Given this list of marker genes Fubp1 (far upstream element (FUSE) binding protein 1), Mrpl17, Napa, Trnau1ap, Eprs1, Eif3c, Gmppb, Sema4d, Tcof1, Nop14, Eif3j1 (NCBI Gene Id 98779), Rflnb, Uqcr10, Cd79b, Hipk2, Hsp90ab1 (NCBI Gene Id 98078), Ndufs2, Socs1, Nsun2, Pax5, Kras, Psma6, Llph (NCBI Gene Id 66225), Ran, Cyp51, Ascc3, Zc3h15, Ddx50, Chchd1, Fam136a, Ptpn2, Ptges3, Esf1 (NCBI Gene Id 99391), Ruvbl1, Taf1d, Mrpl54, Ppan, Camk2d, Btf3, M6pr, Nedd9, Cars1, Ciita, Dnajb11, Pdcl3, Pdcd11, H2-Eb1, Fkbp2, Parl, Psmd2, Hnrnpdl, Tomm40, Rtf1, Cd83, Wdr3, Romo1, Mfsd14a, Slc1a5, Snrpa1, Ddx21, Nsmce1, Hnrnpk, Cyc1, Rbm3, Mybbp1a, H2-DMa, Abcf1, Lamp2, Snrpe, Psmb5, Larp1, Raly, Utp15, Psmg4, Nup43, Sec62, Rrp12, Msh6, Gar1, Plbd1, Crebzf (NCBI Gene Id 70721), Drap1, Brd2, Utp14a, Nubp1, Psmd12, Hyou1, Ppie, Gmps, Jagn1, Abcf2, Psmd6, Noc3l, Cdv3, Timm8b, Timm10, Sigmar1, Elac2, Iars1, Pfdn2, Nol12 (nucleolar protein 12), Htatsf1 (NCBI Gene Id 76595), Psmd11 (proteasome (prosome, macropain) 26S subunit, non-ATPase, 11), Nip7, Psmc3, Atp5pf, Eif3b, Atic, Slc9a8, H2-Ab1, Cdk4, Ddit3, Rrs1, Naa20, Xpot, Atp5mc1, Bsg, Nolc1, Slc35b1, Nucks1, Atf4, Atp2a2, Timm8a1 (NCBI Gene Id 30058), Polr1g, Sbno1, Hdgf, Tkt, Bccip, Banf1, Cebpz, Syncrip, Agpat5, Hsp90b1, Las1l, Cops4, Pebp1, Ccdc86, Map4k1, Ndufa1, Ezr, Idi1, Jund, Mir142hg, Cetn3 (NCBI Gene Id 12626), Ndufa12, Nop2, Pip4p1, Eif2s1, Tmed10, Srsf9, Chmp4b, Lsm12, Txndc15, Ppp3cc, Nudt21, Rpf2, Atp5f1e, Rexo2, Tomm6, Rad23a, Sf3b3, Hnrnpa3, Sra1, Atp5f1b, Psme2, Wdr18, Kpnb1, Tmed2, Cycs, Smc1a, Dhx40, Rnf7, Smyd5, Tmed8, Wdfy2, Bub3, P4hb, Srsf6, Rrp9, Cfl1, Anp32b, Nudc, Pprc1, Tmem258, Snrpa, Psmb6, Pdap1, Tcf12, Slc7a1, Bag5, Eno1, Xbp1, Psmb3, Trmt61a, Ctsz, Ndufa5, Sdf2l1, Gpatch4 (G patch domain containing 4), Kti12, G3bp1, Eftud2, Ufm1, Eif4a3, Cltc, Rcl1, Exosc1, Srsf7 (NCBI Gene Id 60426), Mrto4, Zfp593, Cdk2ap1, Zfp62, Isca2, Wdr74, Rrp15, Klhdc2, Sar1a, Tma16, Fasn, Mrpl3, Dcun1d5, Metap2, Xylt1, Srrm1, Ssr4, Mars1, Bcl7c (NCBI Gene Id 233901), Prelid3b, Hspd1, Set, Snrpd2, Sumo2, Pelp1, Serbp1, Mrps17, St7, Ybx1, Usp10, Srm, Ifi35, Prmt7, Eif4g1, Pxdc1, Eef1b2, Htt, Rnmt, Taf4, Ldha, U2af2, Ass1, Hmgb1, Noc2l, Rrp1, H2-DMb1, Rbm8a, Dock10, Gars1 (NCBI Gene Id 353172), Rce1, Atg3, Ppp1r15b, Rbm19, Ddx39a, Nat10, Ints6, Wdr75, Lman2, Mettl1, Rbmxl1, Snrpb, Tmem123, Snx8, Uqcr11, Cct3, Snrpf, C1qbp, Ostc, Psmb7, Manf, Slc15a3, Cstf2t, Samsn1, Ube2i, Canx, Mrpl55, Ube2s, Mogs, Stt3b, Psmb2, Ppig, Eif3a, Pla2g12a, Cct2, Spcs3, Pdia3, Eif1a, Thap12, Ncoa3, Mfsd5, Aggf1, U2af1, H2-Aa, Vars1, Hnrnpd (NCBI Gene Id 330135), Uqcrb, Eif5b, Tgfbr1, Npm3, Eif2s3x (eukaryotic translation initiation factor 2, subunit 3, structural gene X-linked), Psmd7, Ubl4a, Bola2, Hspa5, Sdad1, Mthfd2 (NCBI Gene Id 17768), Ccdc115, Ankrd49, Eif2s2, Hnrnpa0, Sars1, Dhx15 (DEAH-box helicase 15), Otulin, Apex1 (apurinic/apyrimidinic endonuclease 1), Wdr46, Atp5f1c, Ubxn4, Rbm17, Bmp2k (BMP2 inducible kinase), Dnajc2 (DnaJ heat shock protein family (Hsp40) member C2), Fdps, Ndufb2, Glrx3, Gspt1, Spcs2, Atp5mc3, Pou2af1, Rheb, Pes1, Nifk, Nmt1, Cox5a, Gtf2f1, Pdia4, Fbxo28, Usp4, Nhp2, Golga4, Gnl3, Polr1f, Idh3b, Syngr2, Vmp1, Pgam1, Senp6, Vkorc1l1, Diablo, Nr2c2ap, Vcp, Smim7, Snrpd3, Nme1, Ctu2, Psma7, Eif4e2, Mcm5, Sem1, Rasa2, Tuba4a, Foxn3, Nob1, Alkbh1, Mrpl35, Chchd2, Cct8, Mrfap1, Mrps18a, Srpk1, Hnrnpa2b1, Vapa, Fbxw7, Hspe1, Prdx1, Arhgdia, Rsl1d1, Ccdc59, Trappc4, Ak2, Nudt19, Hsd17b12, Cnr2, Tars1, Cfdp1, Erh, Ranbp1, Ssb, Npm1, Snx29, Snrpd1, Samm50, Psma3 (NCBI Gene Id 19167), Ppp3ca, Lsm7, Bud31, Eif2b5, Eif4e, Scamp2, Bzw1, Il4ra, Bcl6, Kcnq1ot1, Tcerg1, Glipr2, Hvcn1, Ube2l3, Dapk3, Coro2a, Nup62, Ap1m1, Hnrnpf, Srsf2, Wdr4, Etfa, Ormdl2, Cyb561d2, Arap2, Cct5 (chaperonin containing TCP1 subunit 5), Fbl, Uqcrq, Mrpl42 (mitochondrial ribosomal protein L42), Wdr43, Hnrnpu, Tasor2, Aprt, Actg1, Top1, Txn2, Dcaf13, Exosc10, Alyref, Pkib, Mrpl12, Dhps, Elob, Nipsnap3b, Spag7 (NCBI Gene Id 216873), Rnf4, Nfx1, R3hdm1, Snu13, Nop10, Rrp1b, Eif1, Ptma, Pak1ip1, Osgep, Stoml2, Il4i1, Ctps1, Uqcc4, Rbm15b, Ddost, Abhd18, Cox7b, Mrps18b, H2-Eb2 (NCBI Gene Id 631971), Srsf5 (NCBI Gene Id 20384), Ppid, Rpn1, Ltv1 (NCBI Gene Id 353258), Rsl24d1, Timm13, Dazap1, Abce1, Por, Ski, Pus7, Tsn, Lmo2, Eef1e1, Mrpl51, Utp18, Caprin1, Brix1, Srsf3, Cd74, Rangap1, Matr3, Nol9, Hspa8, Yy1, Ak6, Gng5, Mif, Ncl, Dnaja2, Kars1, H2-DMb2, Mgat2, Mak16, Impdh2, Mapre1, Pih1d1, Pum3, Ndufab1, Nol8, Gcn1, Pxk, Sypl1, Ap1b1, Eif5a, Aldh18a1, Ppa1 (pyrophosphatase (inorganic) 1), Phb1, Calr, Shmt2 (NCBI Gene Id 72410), Pole4, Bcar3, Pno1, Mtch2, Mrpl23, Msmo1, Rcc2, Atp5mk, Yars1, Ssr1, Oxa1l, Cdc5l, Stap1, Larp4, Map3k8 (mitogen-activated protein kinase kinase kinase 8), Ndufb7, Pa2g4, Zbtb11, Lap3, Rmi2, Gapvd1, Ddx10, Prpf8, Gtpbp4, Psma2, Cnot4, Gapdh, Aamp, Cct4, Trp53, Tmed9 (NCBI Gene Id 67511), Cox5b, Hspa4, Lyar, Mtx1 (NCBI Gene Id 17827), Mdn1, Sgta, Lsm2, Ndufaf8, BC035044, Nars1, Sarnp, Chfr, Mif4gd, Clic4, Exosc2, Utp11, Gnl2 (guanine nucleotide binding protein nucleolar 2), Dkc1, Etf1 (NCBI Gene Id 52117), Tmem147, Atp5pb, Pfdn6, Phgdh (NCBI Gene Id 50895), Rpn2, Ppia, Cnbp, Slc25a5, Psmc5, Gadd45g, St13, Rars1, Ipo5, Eif3l, Znrd2, Timm9, Prmt1, Rab35, Klhdc4, Grpel2, Becn1, Stip1, Nktr (natural killer tumor recognition sequence), Ubtf, Hnrnpab, Sephs2, Rwdd4a, Acbd6, Ddx3x, Eif4a1, Tmed5 (NCBI Gene Id 74336), Uxt, Tubb4b, Ebna1bp2, Gcsh, Clptm1l, Magoh, Dctpp1, Trmt1, Sar1b, Clk4, Stub1, Tsr1, Ptrh2, Atp1a1, Polr2f, Cd164, Lsg1 (NCBI Gene Id 52909), Mrpl38, Snrpg, Ube2v2, Tcp1, Sugp1, Pdia6, Hsp90aa1, Mphosph10, Cd53, Atp6v1f, Mrps15, Yrdc, Ost4, Irak1, Mrps24, Txnl4a, Nop56, Nop58, Hspa9, Usp7, Uqcc2, Fen1, Nfkbib, Atad3a, Psmg2, Itfg2, Bax, Psme1, Eloc, Hdlbp, Psma4, Snap23, Ssrp1, Dph5, Pfn1, Prag1, Sdc4, Lars1, St6galnac4, Ppp1r14b, Psma5, here is a description of the gene set: from publication Cui A, Huang T, Li S, Ma A, Pérez JL, Sander C, Keskin DB, Wu CJ, Fraenkel E, Hacohen N (PMID 38057668) Genes positively differentially expressed in cell type: B cell upon treatment with cytokine: IL-4 in mouse lymph nodes in vivo. species: Mus musculus Mouse Gene Set: CUI_B_CELL_IL4_RESPONSE_UP Cytokines mediate cell-cell communication in the immune system and represent important therapeutic targets. A myriad of studies have highlighted their central role in immune function, yet we lack a global view of the cellular responses of each immune cell type to each cytokine. To address this gap, the authors created the Immune Dictionary, a compendium of single-cell transcriptomic profiles of more than 17 immune cell types in response to each of 86 cytokines (>1,400 cytokine-cell type combinations) in mouse lymph nodes in vivo. A cytokine-centric view of the dictionary revealed that most cytokines induce highly cell-type-specific responses. For example, the inflammatory cytokine interleukin-1β induces distinct gene programmes in almost every cell type. A cell-type-centric view of the dictionary identified more than 66 cytokine-driven cellular polarization states across immune cell types, including previously uncharacterized states such as an interleukin-18-induced polyfunctional natural killer cell state.